The following is a description of a gene set: Reactome Pathway: Sensory Perception studied in species Homo sapiens Sensory perception includes the reactions and physical events that are required to receive a stimulus, convert the stimulus to a molecular signal, and sense the signal. This module includes pathways describing the sensory perception of light (visual transduction, reviewed in Grossniklaus et al. 2015, Molday and Moritz 2015, Lankford et al. 2020), volatile chemicals (olfaction, reviewed in Glezer and Malnic 2019, Lankford et al. 2020), tastants (chemicals that activate taste receptors, reviewed in Roper and Chaudhari et al. 2017), and sound., and this is the list of marker genes: BCO2, RDH16, FNTB, TAS2R16, OR2C1, TRPM5, OR8J2, OR10G9, OR2C3, OR52K1, OR4S2, TAS1R3, OR5C1, OR1E3, OR6T1, OR13C2, SYP, OR14A16, OR2M3, OR2W3, RTP2, SCNN1D, OR2G3, SLC24A1, GPC2, TAS2R39, OR5M3, OR5H14, OR14C36, CAPZB, OR52E4, OR4C12, OR10Q1 (olfactory receptor family 10 subfamily Q member 1), OR52M1, GRK1 (G protein-coupled receptor kinase 1), OR6M1, WHRN, OR51T1, OR52A5, OR52B6, OR10R2, OR2J3, OR52A4P, GPC4, OR52E8, OR2K2, OR5AR1, APOA2, OR10V1, OR10G6, OR52B2, OR2T7, OR5B21, PDE6B, OR5B2, APOM, OR10H4, OR2AJ1, OR5J2, OR1J4 (olfactory receptor family 1 subfamily J member 4), GUCA1B, OR5L2, OR7C1, TAS2R38, OR5M1, OR56A3, KCNJ2, OR4D6, OR2AG1, CALM1 (calmodulin 1), OR13H1, GPC5, OR4A15, OR2A1, ESPN, OR2M5, OR51J1, OR51S1, OR10AC1, OR9Q2, CALHM1, OR1J2, OR8J1, OR8G1, ATP2B1, SLC26A5, GNAL, TAS2R40, ACTB, OR8I2, OR2T12, OR51I1, SCN2B, TAS2R1, OR11G2, OR4D10, CACNA2D2, OR52L1, OR4A8, OR5T1, SDR9C7, OR10W1, OPN1MW, SPTBN1, CAPZA1, PNLIP, OR13D1, OR2M2, OR10AG1, OR12D2, OR8B4, OR5D16, OR5B3, OR2B11, LHX2, OR10D3, OR5L1, OR1G1, OR10A4, OR51F2, ANO2, GPC3, OR5AS1, OR10G7, OR4K5, OR5H15, OR7G3, OR6N1, OR10G4, GRK4, PLCB2, OR2G2, OR52R1, DNAJC5, GNB5, OR4C15, OR5M11, GPC1, OR6C74, RAB3A, OR5T3, TAS2R30, OR1D2, KCNQ4, OR7G1, OR8D1, OR6K2, OR52E5, OR2T1, STRC, CHRNA10, LDB1, OR2I1, PDE6G, OR1L3, OR13C5, OR56A5, OR5T2, RHO, OTOP1 (NCBI Gene Id 133060), OR5AN1, AKR1C4, RTP1 (receptor transporter protein 1), OR5AC1, RDH5, OR4N4, OR5K3, VAMP2, AKR1C3 (NCBI Gene Id 96424), CALHM3, OR4K15, OR2J1, CAMKMT (calmodulin-lysine N-methyltransferase), MYO7A, KCNMA1 (NCBI Gene Id 3778), OR6Q1, OR1L8, OR4X2, OR6J1, OR51F1, OR9I1, OR51B2, OR6P1, OR51E2, SCNN1G, OR52E6, NMT2, TMC1, OR11H2, OR7D2, OR10S1, GRM1, OR52K2, CNGA4, HSPG2, OR5H1, OR9G9, OR7A17, OR6B1, OR4K14, OR6B3, GRXCR2, OR6X1, OR10A2, OR4D2, OR52N2, OR1P1, OR7C2, RDH8, OR10A7, OR1D4, OR11H7, OR4F6, OR14K1, TAS2R46, OR4A4P, OR2T2, OR6K3, OR51V1, OR8B2, OR51M1, OR51B5, OPN1LW, MYO1C, EPS8L2, OR51A2, OR11H4, OR6C6, SNAP25, TAS2R50, TAS2R8, OR6C75, DHRS3, OR4A47, OR2A14 (olfactory receptor family 2 subfamily A member 14), OR6C4, OR11H1, OR2B6, EPB41L3, OR10A6, OR8U9, SCN1B, OR10H5, OR4C13, OR6C76, DHRS9 (dehydrogenase/reductase 9), OR2B2, SCNN1A, OR13C9, OR4A5, OR1N2, OR4C45, BSN, RBP2, CABP2, OR2V2, CABP1, OR7A2P, OR13J1, CIB2, OR4K13, LRRC52, OR51G2, OR51I2, OR4Q3, TAS2R5, LRAT, OR3A1, OR2M7, OR4C5, GUCA1C, OR8H3, OR4D11 (NCBI Gene Id 81306), LRP10, RDH12, TAS2R10, HSD17B1, RETSAT, CASK, RDH10, OR4F4, STX1A, OR5M10, ATP2B2, OR9A4, OR4F17, OR4K2, OR4F5, OR1S2, MPP1, GPIHBP1, OR3A3, PLS1, MYO3B, OR13G1, OR1A1, OR5AP2 (olfactory receptor family 5 subfamily AP member 2), OR2F1, OR51G1, RDX, TAS2R31, OR4S1, OR2L3, TTR, EBF1, OR1Q1, OR10A3, OR2J2, RLBP1, BCO1, OR8G2P, GUCA1A, OR52W1, OR52D1, OR9A2, OR5M8, HSD17B6, OR8B8, OR10Z1, SAG, PDE6A, TAS2R3, OR6C3, CTBP2, OR4L1, OR9G1, OR10H3, OR9K2, OR2A2, OR2T6, OR5F1 (olfactory receptor family 5 subfamily F member 1), OTOG, METAP2, PLB1, OR2T35, OR4F15, TAS2R4, OR2L13, OR2A25, OR1J1, OR7A10 (NCBI Gene Id 390892), OR8J3, OR8B3, OR2L8, LDLR, OR5M9, OR11H6, AKR1C1, OR5I1, TMIE, OR2D3, APOA4, OR52E1, OR5AC2, OR2Y1, OR2T34, KCNMB1, OR4E1, OR51Q1, OR5K2, OR5D14 (olfactory receptor family 5 subfamily D member 14), OTOGL, OR7E24, AKR1B10, APOE, OR10H2, OR4Q2, OR2S2, OR5AK2, APOA1 (apolipoprotein A1), OR5D18, OR2M4, REEP1, OR2A4, OR1B1, OR10A5, OR12D3, LPL, CHRNA9, OR10C1, GNG13, OR4N5, RPE65, OR13A1, TAS2R14, OR2AT4, OR6N2, OR8K5, OR6V1, FSCN2 (fascin actin-bundling protein 2, retinal), OR52I1, LRP12, OR14J1 (olfactory receptor family 14 subfamily J member 1), RBP1, OR2T11, OR1K1, OR5K1, OR52E2, OR6B2, CACNA1D, OR4K3, OR1L1, OR2L5, OR1C1, OR4C46, GUCY2F, OR10P1, FNTA, OR2H1 (NCBI Gene Id 81408), OR4D5, OTOF, OR52A1, OR5AU1, CNGA1, OR5B12, OR2T5 (olfactory receptor family 2 subfamily T member 5), GSN, OR4K1, OR10K1, OR2W5P, ABCA4, OR52Z1P, SYN1, OR1F12P, OR10J5, OR4M2, OR6C70, OR5P3, OR14I1, OR11A1, OR2T29, SDC1, OR4M1, OR1A2, CAPZA2, SLC17A8, SCN3A, OR8G5, OR7A5, OR6K6, OR4K17, GNAT1, TAS2R13, SCN2A, OR2AG2, OR4N2, CLIC5, OR51H1, MSN, TMC2, OR51B6, OR5H2, RGS9BP, OR6A2, OR10X1, OR10J1, OR2A7, OR2T33, OR5H6 (NCBI Gene Id 79295), OR6Y1, OR56A4 (NCBI Gene Id 79271), RBP4, TRPM4, EPS8, USH1G, SDC4, ITPR3, OR6C68, OR10AD1, LHFPL5, OR2T10, OR2AK2, OR4C6, OR52N5, SCN4B, OR5A1, OR51B4, OR1E2 (olfactory receptor family 1 subfamily E member 2), OR2Z1, TAS2R20, OR6F1, ESPNL, OR51A4, OR1L6, GRXCR1, OR2L2, KCNN2, APOC3, OR1N1, OR2H2, OR1S1, OR10H1, APOB, TWF2, STRA6, OR4E2, OR1E1, TPRN, OR4C11, OR4C16, TAS2R7, OR5AL1, MYO15A, ACTG1, OR2V1, NMT1, OR9Q1, OR4F21, OR2G6, METAP1, OR5V1, OR11L1, OR52L2P (NCBI Gene Id 79274), OR4X1 (NCBI Gene Id 79472), SPTAN1, OR8K1, OR4D9, OR13C4, OR8B12, OR51L1, OR52N1, OR8K3, OR2AP1, EZR, OR2A12, OR8H2, LRP2, LRP1, OR1D5, CNGB1, OR2T8, OR6S1, CACNB2, OR52N4, OR5D13, OR51A7, OR56A1, OR8D4, OR7G2, OR1I1, OR7D4, OR10G3, OR2A5, OR2T4, OR2D2, RIPOR2, GUCY2D, OR8D2, RBP3, OR5W2, GNB1 (G protein subunit beta 1, NCBI Gene Id 87729), OR5P2, OR5G3, OR8A1, OR4C3, OPN1SW, PCLO, TWF1, OR52J3, OR2AE1 (olfactory receptor family 2 subfamily AE member 1), OR13C3, RDH11, OR8H1 (olfactory receptor family 8 subfamily H member 1), OR10T2, CYP4V2, OR52Z1, OR2T3, OR5A2, ADCY3, GNB3, CDH23, EPB41L1 (NCBI Gene Id 23260), OR4B1, GRK7, RCVRN, OR13F1, OR3A2, TRIOBP, OR1F12, OR56B1, SCN9A, OR13C8, OR51E1, OR6C2, OR1F1, OR8S1, OR9G4, OR6C1, OR2W1, OR4F3, OR10G2, CNGA2, TAS2R43, OR8U8, OR1M1 (NCBI Gene Id 26730), OR4A16, PCDH15, OR52H1, SCNN1B, RGS9, LRP8, OR10G8, AGRN, MYO3A, PRKCQ, PPEF1, OR10J4, OR14A2, AWAT2, TAS2R41, XIRP2, OR51D1, PJVK, SDC3, OR8U1, PRKCA, GNAT3, GRM4, OR4P4, SDC2, TAS1R2, OR1L4, OR52I2, OR8U3 (NCBI Gene Id 79485), OR5K4, TAS1R1, OR2B3, MYH9, OR10J3, OR6C65, APOC2, CLPS, OR56B4, OR2T27, GPC6, OR5B17, USH1C, OR2F2, OR10K2, GNGT1, OR4D1